Given this list of marker genes UQCRH, UQCC3, UQCR10 (ubiquinol-cytochrome c reductase, complex III subunit X), UQCRC2, MT-CYB, UQCR11, CYCS, UQCRC1, UQCRB, UQCRQ, UQCRHL, CYC1, UQCRFS1P1, UQCRFS1, here is a description of the gene set: studied in species Homo sapiens Human Gene Set: GOBP_MITOCHONDRIAL_ELECTRON_TRANSPORT_UBIQUINOL_TO_CYTOCHROME_C The transfer of electrons from ubiquinol to cytochrome c that occurs during oxidative phosphorylation, mediated by the multisubunit enzyme known as complex III.